The following is a description of a gene set: studied in species Homo sapiens Reactome Pathway: Sodium/Proton exchangers The SLC9 gene family encode proteins (sodium/proton exchangers, NHE or NHX) which exchange sodium (influx) for protons (efflux) electroneutrally. This mechanism is important because many metabolic processes generate acids which need to be removed to maintain pH. This is the major proton extruding system in cells, driven by the inward sodium ion chemical gradient. To date, there are eleven NHE genes, NHE1-11. NHE1-5 exchange cations at the cell membrane. NHE6-9 exchange cations at endosomal membranes or the trans-golgi network membranes. part of: Metal ion SLC transporters, and this is the list of marker genes: SLC9A5, SLC9A9, SLC9A3, SLC9A4, SLC9A1, SLC9A6, SLC9A8, SLC9A2, SLC9A7